Given this list of marker genes DEPDC1B, SKA1, KIF14, TSR1, KPNA2, CCNB2, TYMS, DSCC1, CCDC34, RACGAP1, PRR11, MPC2, CCNB1, NUF2, NEK2, MCM10, ZWILCH, ASPM, UBE2T, BUB1B, DLGAP5, GAGE1, TRIP13, UBE2C, EZH2 (NCBI Gene Id 392834), FANCI, FOXM1, AURKA, BIRC5, SPC24, TPX2, RFC4, E2F8, SLC19A1 (NCBI Gene Id 6573), TOP2A, PRC1, TTK, CENPL, NUSAP1, FAM72C, SPC25, RRM2, CDK1, MAGEA3, MAGEA1, PCLAF, here is a description of the gene set: To better define the molecular basis of multiple myeloma (MM), we performed unsupervised hierarchic clustering of mRNA expression profiles in CD138-enriched plasma cells from 414 newly diagnosed patients who went on to receive high-dose therapy and tandem stem cell transplants. Seven disease subtypes were validated that were strongly influenced by known genetic lesions, such as c-MAF- and MAFB-, CCND1- and CCND3-, and MMSET-activating translocations and hyperdiploidy. Indicative of the deregulation of common pathways by gene orthologs, common gene signatures were observed in cases with c-MAF and MAFB activation and CCND1 and CCND3 activation, the latter consisting of 2 subgroups, one characterized by expression of the early B-cell markers CD20 and PAX5. A low incidence of focal bone disease distinguished one and increased expression of proliferation-associated genes of another novel subgroup. Comprising varying fractions of each of the other 6 subgroups, the proliferation subgroup dominated at relapse, suggesting that this signature is linked to disease progression. Proliferation and MMSET-spike groups were characterized by significant overexpression of genes mapping to chromosome 1q, and both exhibited a poor prognosis relative to the other groups. A subset of cases with a predominating myeloid gene expression signature, excluded from the profiling analyses, had more favorable baseline characteristics and superior prognosis to those lacking this signature. from publication Zhan F, Huang Y, Colla S, Stewart JP, Hanamura I, Gupta S, Epstein J, Yaccoby S, Sawyer J, Burington B, Anaissie E, Hollmig K, Pineda-Roman M, Tricot G, van Rhee F, Walker R, Zangari M, Crowley J, Barlogie B, Shaughnessy JD Jr (PMID 16728703) Human Gene Set: ZHAN_MULTIPLE_MYELOMA_PR_UP studied in species Homo sapiens Top 50 up-regulated genes in cluster PR of multiple myeloma samples characterized by increased expression of proliferation and cell cycle genes.